The following is a description of a gene set: The repair of UV-induced T-T, C-T and C-C dimers. species: Homo sapiens Human Gene Set: GOBP_PYRIMIDINE_DIMER_REPAIR, and this is the list of marker genes: DDB2, CRY2, SIRT1, HMGN1, XPC, POLH, ERCC1, ERCC6, POLB